The following is a description of a gene set: species: Mus musculus Mouse Gene Set: GOBP_REGULATION_OF_SKELETAL_MUSCLE_SATELLITE_CELL_PROLIFERATION Any process that modulates the frequency, rate or extent of skeletal muscle satellite cell proliferation., and this is the list of marker genes: Mstn, Fgf2, Akirin1, Jak2, Six5, Angpt1, Ppard, Cflar, Ephb1, Six1, Paxbp1, Myog, Stat3